The following is a description of a gene set: Human Gene Set: REACTOME_HSF1_DEPENDENT_TRANSACTIVATION studied in species Homo sapiens HSF1-dependent transactivation, and this is the list of marker genes: HSP90AA1, HSBP1, HSPA1B, CAMK2B, CRYAB, HSPB1, MTOR, HSPA8, HSPA2, HSPA6, AKT1S1, MLST8, CRYBA4, SERPINH1, HSF1 (heat shock transcription factor 1), CAMK2G, FKBP4, COL4A6, DEDD2, HSP90AB1, GML, RLN1, DNAJB1, UBB, HSPA1L, HSPA1A, CREBBP, CAMK2D, TNFRSF21, RPTOR, HSPB8, PTGES3, EP300, HSPH1, HSPB2, CAMK2A, MRPL18, DNAJB6